Given this list of marker genes Spdya, Acd, Dclre1b, Terf1, Potefam3a, Pkib, Pnkp, Tnks2, Hnrnpa2b1, Mre11a, Rtel1, Nbn, Potefam3b, Xrcc1, Ankrd66, Mapk1, Pot1a, Mapk3, Nek2, Pot1b, Prkcq, Atm (NCBI Gene Id 77416), Xrcc4, Hnrnpd, Smg6, Terf2, Map3k4, Rad50, Prkdc, Ercc1, Nabp2, Nek7, Aurkb, Mapk15, Map2k7, Ercc4, Stn1, Tinf2, Terf2ip, Tnks, Mapkapk5, here is a description of the gene set: Mouse Gene Set: GOBP_TELOMERE_CAPPING A process in which telomeres are protected from degradation and fusion, thereby ensuring chromosome stability by protecting the ends from both degradation and from being recognized as damaged DNA. May be mediated by specific single- or double-stranded telomeric DNA binding proteins. species: Mus musculus